The following is a description of a gene set: Catalysis of an oxidation-reduction (redox) reaction in which hydrogen or electrons are transferred from reduced pteridine and one other donor, and one atom of oxygen is incorporated into one donor. studied in species Mus musculus Mouse Gene Set: GOMF_OXIDOREDUCTASE_ACTIVITY_ACTING_ON_PAIRED_DONORS_WITH_INCORPORATION_OR_REDUCTION_OF_MOLECULAR_OXYGEN_REDUCED_PTERIDINE_AS_ONE_DONOR_AND_INCORPORATION_OF_ONE_ATOM_OF_OXYGEN, and this is the list of marker genes: Th, Pcbd2, Pcbd1, Park7, Agmo, Pah, Tph2, Tph1